Given this list of marker genes TNFSF13, CLEC10A, FYB1, TNFAIP2, SLC38A1, KIF17, S100A8, MN1, DYNLT1, CFP, ST18, AK5, MDFIC, IGKV1D-17, CBFB, CLEC7A, MYH11 (NCBI Gene Id 4629), IL10RA, QPCT, CD1C, PLXNB2, CD52, LPAR1 (NCBI Gene Id 1902), CTSS, NACC2, SPARC, TGFBI, IL13RA1, LGALS2 (galectin 2), HPCAL1, NRP1, CLEC4A, MEGF9, GRHPR, PGM1, NAGA, CD1E, SLC7A7, TES, CEBPD, PLBD1, CCR2, CYBB, MEF2A, GIMAP4, PTPRM, DUSP6, S100A9, CHI3L1, KCTD12, ANXA11, MTMR11, here is a description of the gene set: species: Homo sapiens from publication Ross ME, Mahfouz R, Onciu M, Liu HC, Zhou X, Song G, Shurtleff SA, Pounds S, Cheng C, Ma J, Ribeiro RC, Rubnitz JE, Girtman K, Williams WK, Raimondi SC, Liang DC, Shih LY, Pui CH, Downing JR (PMID 15226186) Contemporary treatment of pediatric acute myeloid leukemia (AML) requires the assignment of patients to specific risk groups. To explore whether expression profiling of leukemic blasts could accurately distinguish between the known risk groups of AML, we analyzed 130 pediatric and 20 adult AML diagnostic bone marrow or peripheral blood samples using the Affymetrix U133A microarray. Class discriminating genes were identified for each of the major prognostic subtypes of pediatric AML, including t(15;17), t(8;21), inv(16), MLL chimeric fusion genes, and cases classified as FAB-M7. When subsets of these genes were used in supervised learning algorithms, an overall classification accuracy of more than 93% was achieved. Moreover, we were able to use the expression signatures generated from the pediatric samples to accurately classify adult de novo AMLs with the same genetic lesions. The class discriminating genes also provided novel insights into the molecular pathobiology of these leukemias. Finally, using a combined pediatric data set of 130 AMLs and 137 acute lymphoblastic leukemias, we identified an expression signature for cases with MLL chimeric fusion genes irrespective of lineage. Surprisingly, AMLs containing partial tandem duplications of MLL failed to cluster with MLL chimeric fusion gene cases, suggesting a significant difference in their underlying mechanism of transformation. Human Gene Set: ROSS_AML_WITH_CBFB_MYH11_FUSION Top 63 probe sets for pediatric acute myeloid leukemia (AML) subtype inv(16); has a CBFB-MYH11 fusion.